The following is a description of a gene set: Mouse Gene Set: GOBP_REGULATION_OF_LYMPHOCYTE_DIFFERENTIATION studied in species Mus musculus Any process that modulates the frequency, rate or extent of lymphocyte differentiation., and this is the list of marker genes: Zfp35, Cd27, Klhl25, Zeb1, Pnp, Ptpn2, Smarcd3, Lag3, Fanca, Sash3, Ccr7, Pf4, Ptpn6, Ada, Smarcd1, Adam8, Tnfsf18, Spi1 (NCBI Gene Id 20375), Id2, Tbx21, Tgfb1, Rorc, Il7, Anxa1, Shh, Drosha (drosha, ribonuclease type III), Pbrm1, Ikzf3, Flt3l, Actb, Bcl6, Fancd2, Il6, Prdx2, Rc3h1, Zap70, Rc3h2, Syk, Ddrgk1, Rag1, Egr3, Smarca2, Ctla4, Jak3, Opa1, Pglyrp3, Il2, Brd4, Sox13, Smarcc2 (NCBI Gene Id 68094), Il15ra, Il15, Gimap3, Sox12, Zc3h12a, Malt1, Socs1, Ctla2a, Slc46a2, Nfkbiz, Nkap, Zfp608, Arid1a, Ap3d1, Prkdc, Ankle1, Hspb1, Socs5, Kat2a, Clptm1, Nfkbid, Sh2b3, Fbxo7, Prelid1, Il10, Ifnb1, Mir326, Itpkb, Prkcz, Braf, Sox4, Sart1, Slamf8, Lck, Sh3rf1, Vnn1, Il36b, Crtam, Kat5, Gimap5, Lef1, Smarcd2, Inpp5d, Cd44, Rasgrp1, Ccl20, Foxo3, Gli3, Il23a, Cd74, Tcf7, Il27, Vsir, Il4ra, Foxn1, Hlx, Tlr9, Cdkn2a, Dusp10, Duxbl1, Lilrb4a, Erbb2, Abl1, Atp11c, Smad7, Ccr2, Zfp36l2, Brd2, Card11, Ptprc, Hmgb1, Rag2, Lgals1, Mir150, Pck1, Ccr6, Ap3b1, Cd46, Smarce1, Runx1, Zc3h8, Lgals9, Zfp36l1, Skint1, Tnfsf4, Cd69, Hsp90aa1, Sos2, Rhoh, Tgfbr2, Sfrp1, Il12a, Bmp4, Foxj1, H2-Oa, Cyld, Phf10, Gas6 (NCBI Gene Id 14456), Nlrp3, Hmgb3, Cd24a, Ascl2, Il2rg, Zmiz1, Loxl3, Pglyrp2, Cd83, Il7r, Sos1, Il4i1, Cbfb, Bad, Foxp3, Rhoa, Nckap1l, H2-Ea (histocompatibility 2, class II antigen E alpha), Cd1d1, Tespa1, Actl6b, Tox, Wnt10b, Arid2, Il4, Ccl19, Kcnk18, Fgl2, Il1rl2, Ripk2, Cyp26b1, Rara, Lilrb4b, Fas, Mmp14, Ihh, Irf1, Ep300, Smarcc1, Brd7, Xrcc6, Rnf41, Pglyrp1, Zfp609, Smarcb1, Mir301, Nrarp, H2-Aa (NCBI Gene Id 406213), Zbtb7b, Xbp1, Nfam1, Carmil2, Gata3 (GATA binding protein 3), Prdm1, Actl6a, Ambra1, Shb, Tnfsf9, Pik3r6, Smarca4, Ppp2r3c, Dicer1, Clec4g, Dtx1, Il2ra, Il21, Runx3, Axl, Il18, Zfp683, Stat5b (NCBI Gene Id 20851), Mdk, H2-M3, Ifng, Cd28, Ndfip1, Slc4a2, Stat5a, H2-DMa, Pglyrp4, Flt3, Btn2a2, Adrm1, Zbtb1 (zinc finger and BTB domain containing 1), Mettl3, Tmem131l, Pcid2